Given this list of marker genes Fyn, Yes1, Ngef, Efna2, Epha2, Epha7, Efna4, Efna5 (NCBI Gene Id 13640), here is a description of the gene set: Reactome Pathway: EPHA-mediated growth cone collapse electronically inferred by orthology from the curated human pathway This event has been computationally inferred from an event that has been demonstrated in another species.<p>The inference is based on the homology mapping from PANTHER. Briefly, reactions for which all involved PhysicalEntities (in input, output and catalyst) have a mapped orthologue/paralogue (for complexes at least 75% of components must have a mapping) are inferred to the other species. part of: EPH-Ephrin signaling studied in species Mus musculus